The following is a description of a gene set: Human Gene Set: GOBP_ENDOCARDIAL_CUSHION_TO_MESENCHYMAL_TRANSITION A transition where an endocardial cushion cell loses apical/basolateral polarity, severs intercellular adhesive junctions, degrades basement membrane components and becomes a migratory mesenchymal cell. studied in species Homo sapiens, and this is the list of marker genes: ENG, ACVRL1, EFNA1, TWIST1, HEY2, HAS2